The following is a description of a gene set: species: Mus musculus Mouse Gene Set: GOBP_ENDOTHELIAL_CELL_CHEMOTAXIS The directed movement of an endothelial cell guided by a specific chemical concentration gradient. Movement may be towards a higher concentration (positive chemotaxis) or towards a lower concentration (negative chemotaxis)., and this is the list of marker genes: Hmgb1, Hrg, Plekhg5, Nr4a1, Nrp1, Fgf2, Vegfa, Egr3, Snai2, Fgfr1, Gab1, Fgf18, Fgf4 (NCBI Gene Id 14175), Notch1, Prkd2, Fgf1, Kdr, Lgmn, Met, Rab13, Coro1b, Shh, Thbs1 (thrombospondin 1), Prkd1, Smoc2, Cxcl13, Sema5a, Fgf16, Tmsb4x, P2rx4 (NCBI Gene Id 52272), Hspb1, Ccn3